Given this list of marker genes Atp2b1, Ddn, Shisa7, Gria1, Shisa8, Atp2b2, Gper1, Kcnc3, Shisa9, Dagla, Itga8, Slc9a5, Atp6ap2, Trpv1, Akap5, Palm, Shisa6, Ppp1r9b, Clcn2, here is a description of the gene set: The portion of the plasma membrane surrounding a dendritic spine. studied in species Mus musculus Mouse Gene Set: GOCC_DENDRITIC_SPINE_MEMBRANE